The following is a description of a gene set: Binding to a ubiquitin-specific protease. species: Mus musculus Mouse Gene Set: GOMF_UBIQUITIN_SPECIFIC_PROTEASE_BINDING, and this is the list of marker genes: Sart3, Derl1, Prkn, Chmp3, Spata2, Hdac3, Park7, Rad23a, Lcor, Selenos, Bag6, Cltc, Syvn1, Sumo1, Vcp, Nherf4 (NCBI Gene Id 170761), Marchf6, Pten, Amfr